The following is a description of a gene set: The chemical reactions and pathways involving ketone body. Human Gene Set: GOBP_KETONE_BODY_METABOLIC_PROCESS species: Homo sapiens, and this is the list of marker genes: ACAT1, ACSS3, OXCT2, OXCT1, TYRP1, HMGCS2, HMGCL, SLC27A5, HMGCLL1, AACS